The following is a description of a gene set: Any process that modulates the frequency, rate or extent of a response to nutrient levels. Mouse Gene Set: GOBP_REGULATION_OF_RESPONSE_TO_NUTRIENT_LEVELS studied in species Mus musculus, and this is the list of marker genes: Snai2, Snw1 (NCBI Gene Id 66354), Gdf15, Ppara, Lep, Gh, Rxra, Cyp27b1, Ghr, Gfral, Gcg, Ghrl, Oprm1, Bbs4, Prkag2, Cck, Ghsr, Trim24, Npff, Med1, Npy (neuropeptide Y), Mt3, Prkag1, Mtor, Spx, Ucn, Nenf, Bax, Mkks, Nucb2, Pyy, Fbn1, Bcl2, Prkag3, Vdr, Bbs2 (Bardet-Biedl syndrome 2), Rxrb, Nr1h4, Kank2, Prkcg, Cartpt, Or4m1, Mn1